The following is a description of a gene set: Mouse Gene Set: GOBP_FATTY_ACYL_COA_BIOSYNTHETIC_PROCESS studied in species Mus musculus The chemical reactions and pathways resulting in the formation of a fatty-acyl-CoA, any derivative of coenzyme A in which the sulfhydryl group is in thiolester linkage with a fatty-acyl group., and this is the list of marker genes: Acat1, Acsl6, Acsl4, Elovl6, Elovl3, Gcdh, Elovl1, Elovl4, Acsl1, Elovl7 (NCBI Gene Id 74559), Elovl5, Acsl5